Given this list of marker genes ANXA2, APOH, THBD, F9, GGT2P, F11, OMA1, CTSL, PLGRKT, C1R, HPR, CTSH, FGA, HGFAC, PLAU, KLK1, H2BC1 (H2B clustered histone 1), CTSZ, DHCR24, CLEC3B, SERPINE1, FURIN, SERPINE2, ENO1, CUZD1, KLK2, PLAT, KLK3, MELTF, HP, PRSS12, KLKB1, VSIR, F12, PGK1, HPN, SERPINF2, GGT1, PRSS3, PLAUR, FGG, C1RL, S100A10, THBS1, MMP14, FGB, RUNX1, here is a description of the gene set: The proteolytic processing of an inactive enzyme to an active form. studied in species Homo sapiens Human Gene Set: GOBP_ZYMOGEN_ACTIVATION